The following is a description of a gene set: Human Gene Set: GAVISH_3CA_METAPROGRAM_CD4_T_CELLS_INTERFERON studied in species Homo sapiens Genes upregulated in subsets of cells of a given type within various tumors In this study, an extensive analysis was conducted to define meta-programs (MPs) capturing intra-tumor heterogeneity across a spectrum of tumor types. The approach utilized non-negative matrix factorization (NMF) to analyze each cell type separately within individual tumor samples. This involved the analysis of malignant cells, macrophages, fibroblasts, endothelial cells, epithelial cells, T-cells, and B-cells. NMF was executed with varying parameter values (K=4, 5, 6, 7, 8, 9), thereby generating 39 programs for each cell type per sample. Each NMF program was summarized by the top genes based on NMF coefficients.\nRobust MPs were then delineated for each cell type using a set of stringent criteria, including recurrence within the same tumor, similarity to programs in other tumors, and non-redundancy within a tumor. Subsequently, these robust NMF programs were clustered (per cell type) based on Jaccard similarity, leading to the identification of MPs associated with each cell type.\nTo enhance the quality of the MPs, a refinement steps were undertaken, involving the removal of MPs suspected of reflecting low-quality data (with an overrepresentation of ribosomal proteins or mitochondrial-encoded genes), single-study inclusion, or similarity to miss-annotated cell types. from publication Gavish A, Tyler M, Greenwald AC, Hoefflin R, Simkin D, Tschernichovsky R, Galili Darnell N, Somech E, Barbolin C, Antman T, Kovarsky D, Barrett T, Gonzalez Castro LN, Halder D, Chanoch-Myers R, Laffy J, Mints M, Wider A, Tal R, Spitzer A, Hara T, Raitses-Gurevich M, Stossel C, Golan T, Tirosh A, Suvà ML, Puram SV, Tirosh I (PMID 37258682), and this is the list of marker genes: IFI6, TNFSF10, PLSCR1, TRIM22 (tripartite motif containing 22), IRF7, GBP1, MX1, MX2, UBE2L6, SHFL, HSH2D, IFIT3, SAMD9L, NT5C3A, OASL, LAP3, PARP10 (NCBI Gene Id 84875), RIGI, IFI44, EIF2AK2, RTP4, CHST12, CMPK2, STAT1, ZBP1, IFI44L, RSAD2, IFI35, RBCK1, ISG15, PALM2AKAP2, HERC5, PPM1K, USP18, IFIT2, LY6E, OAS3, PARP9, IFIT1, HELZ2, EPSTI1, OAS2, XAF1, OAS1, SP110 (NCBI Gene Id 3436), MT2A, PARP14, ISG20, SAMD9, STAT2